Given this list of marker genes HNF4A, SH3GLB1, ACOX3, FABP5, ALB, FABP1, STX3, FABP4, FABP9, RBP7, ACOX1, PPARD, UGT1A8, FABP3, OXER1, DBT, S100A9, RBP5, FABP7, FABP12, ACOXL, CRABP2, ADH5, APOC1, CRABP1, RBP2, FABP6, FABP5P3, CYP4F11, GSTM2, ALOX5AP, PPARG, FABP2, ID3, PRR7, GSTP1, UCP1, PMP2, SCP2, NDUFAB1, ACOX2 (acyl-CoA oxidase 2), GSTA1, GPR31, RBP1, SNCA, PTGDS, TMEM175, FFAR4, S100A8, here is a description of the gene set: Human Gene Set: GOMF_FATTY_ACID_BINDING species: Homo sapiens Binding to a fatty acid, an aliphatic monocarboxylic acids liberated from naturally occurring fats and oils by hydrolysis.